The following is a description of a gene set: species: Homo sapiens Painful or difficult urination. Dysuria Human Gene Set: HP_DYSURIA, and this is the list of marker genes: IKZF1, HLA-B, CISD2, LAMA3, GPR101, AGXT, HOGA1, APRT, BNC2, LAMB3, AIP, LAMC2, WFS1, HMBS, ALMS1, SPART, CARMIL2, HPRT1